Given this list of marker genes TLR6, IL33, IL4R, JUND, TTBK1, PLA2G4A, CEBPA, TAFA3, MIR128-1, MMP8, TLR4, CTSC, WNT5A, IL13, CCL3, CD200, HSPD1, SPACA3, IL10, TNIP2, LRRK2, KARS1 (NCBI Gene Id 3735), IL1RL1, TREM2, HAVCR2 (hepatitis A virus cellular receptor 2), MIR142, STAP1, LBP, THBS1, MIR145, IRGM, here is a description of the gene set: species: Homo sapiens Any process that stimulates, induces or increases the rate of macrophage activation. Human Gene Set: GOBP_POSITIVE_REGULATION_OF_MACROPHAGE_ACTIVATION